Given this list of marker genes ABCA3, CHAT, SLC9A6, TYMP, CTCF (CCCTC-binding factor), TSEN2, GABRA2, ORC1, CACNA1A, PSPH, CACNA1I, CENPT, GEMIN4, CHD7, ATP11A, CORO1A, DNAAF4, TGIF1, COL5A1, SNAP25, GABRD, CCDC22, FOXG1, ABCD4, WWOX, DYRK1A, ATP7A, DDOST, PLCH1, NRXN1 (NCBI Gene Id 9378), GP1BB, MMP1, TRMT10C, TWNK, PRUNE1, AMER1, TSPYL1, ARSL, TRAPPC12, CDK19, MAP3K7, ARVCF, NTRK2, GBA1, PHOX2B, EDEM3, PIK3CD, SFTPC, ITPR1, SLC6A5, PHGDH, EBF3, ATN1, SLC6A3, NONO, HNRNPH1, CAMTA1, SPTSSA, POGZ (NCBI Gene Id 23126), UFD1, LONP1, VPS35L, VPS37D, ERMARD, FZD2, ZNF699, ZBTB18, TRPV6, COX11, SEC63, FBN1, PGM3 (phosphoglucomutase 3), RREB1, ALG9, NUP62, RPL10, GABRG2 (NCBI Gene Id 2566), DHX9, IL7R, MGAT2, IQSEC2, CLIP2, DPYSL5, FOXP2, CDKN1A, PI4KA, SEC23A, NDUFA13, TRIP4, NALCN, MAPK1, KCNC2, SOX5, KNSTRN, JMJD1C, ALG2, DSP, ARF1, CEACAM6, CDKN2B, TMEM270, RARS2, FGF12, RRM2B, PRMT7, KCNQ3, KMT2A, ELP1, FBXO11, SLC35A2, BAZ1B, CACNA1C, PDPN, CTHRC1, NSUN2, ACTL6B, GTF2I, GABBR2, LETM1, TFAP2A, FZR1, LUZP1, MSL3, SRCAP, SLC38A3, GLYCTK, PARS2, PRKCSH, GLRB, FARSB, POLR2A, ATL1, GABRA5, GRIN1, IFT56, LMNA, DALRD3, PSAP, CRIPTO, IRF5, GRIN2D, ZIC2, KIF1A, CACNA2D1, DPH5, DHDDS, MMP23B (matrix metallopeptidase 23B), SUCLA2, DDB1, PIGT, COL1A1, NSD1, ATP9A, TSEN15, CNTNAP1, GTF2IRD1, TCF4 (transcription factor 4), ZBTB7A, RAI1, SLC25A24, GMNN, ATP6V0A1, HSPG2, ORC4, TCEAL1, FMR1 (fragile X messenger ribonucleoprotein 1), KAT6B, SIX3, METTL27, STIL, SYT1, SEPSECS (NCBI Gene Id 51091), COL7A1 (NCBI Gene Id 1294), TMEM94, HECTD4, APC2, CACNA1B, STAC3, H3-3B (H3.3 histone B), RNU4ATAC, KMT2B, UBA5, FLNA, GRIA1, EXT2, CSPP1, SMC5, SYT2, SCN3A, ADAMTSL2 (NCBI Gene Id 9719), CTBP1, NRCAM, CAV1, BLM, CAMK2B, KDM6A, SMG9, SNRPB, PIEZO2, ERCC8, LYRM4, PTCH1, WNK1, NSD2, ERF, FLCN, ATL3, UFC1, GTF2IRD2, RET, DHCR7, FAM13A, STAG2, ADAT3, SSR4, SFTPA2, CHRNA3, KCNAB2, MRPS34, FOXH1, CCN2, KIAA0586, CHMP1A, HCN1, POR, ADNP, SLC1A2, RNF125, TYMS, MSR1, TRAK1, MUC5B, GNAS, CELF2, DNM1, KCNA2, ASCL1, NPHS1, CLTC, RHBDF2, MYT1L, LRPPRC, WAC, FKBP6, POLG (DNA polymerase gamma, catalytic subunit), SI, KMT2C, GON7, CNKSR2, COL4A6 (collagen type IV alpha 6 chain), MED12, SALL1, PRDM13, SPEN, NUP214, CCDC47, ERCC6, TBC1D24, CPLX1, NODAL, SH2B1, AFF4, SLC26A9, HIRA, CPSF3, SON, AASS, ASCC1, ARCN1, USP7, H3-3A (NCBI Gene Id 3020, H3.3 histone A), KMT2D, TAF1, PACS1, KCNB1, MIF, ATRX, ELN, VAMP1, SRPX2, HDAC8, MAB21L1, NCF1, BRD4, SFTPA1, SLC9A3, COG7 (NCBI Gene Id 91949), SMC3, ASPA, AGRN, ADGRG1, SLC19A2, GNB5, HNRNPH2, PORCN, PHIP, ASXL1 (ASXL transcriptional regulator 1), MED25, PAK1, CFTR, DMPK, PACS2, TOP3A, AARS1, AFF3, TERC, MYH11, SLC18A3, AP3B2, ALDH18A1, WDR26, NUS1, PIEZO1, MAPK8IP3, SMC1A, STAT6, SLC1A4, NUP54, PUF60, PPM1D, EHMT1, SEC24C, KCNH1, ARID2, SLC13A5, CCR6, NECAP1, DCTN4, AGO1, CDON, SYNGAP1, PRDM16 (NCBI Gene Id 647868), ASNS, CDC6, NEPRO, KCNN4, HRAS, SEMA3E, PPP3CA, HLA-DRB1, COL4A5, NOS1, GABRB2, SLC6A14, SPTBN4, TMTC3, LRP5, DISP1, KCNQ2, ADAMTS2, YWHAG, SHH, EP300, DLL1, GRB10, CDK13, SLC25A1, HLA-DQA1, ITCH, MLXIPL, LAMA2, CYFIP2, UBE4B, MAGEL2, TBL2, LTBP4, MBD5, SLC37A4, COMT, SCN9A, ZSWIM6, CDKL5, MID1, EEF1A2, MCEE, SCN8A, TGFB1, RTEL1, ACADVL, SPTAN1, SATB2, TAF6, PCGF2, MECP2, CDKN1B, CLCA4, SKI, CEACAM3, COL5A2, FGFR3, TBX1, STX1A, PRKCZ, LBR, MPV17, ATP1A2, PYCR1, CREBBP, FCSK, GLI2 (GLI family zinc finger 2), GSTM3, USP9X, ADAR, SIAH1, ATP1A3, DST, H4C5, MAP1B, HNRNPK, SLC25A4, CLCN4, SPOP, MEN1, SMARCA2, FGF8, EDNRA, HLA-DQB1, GPHN, COL13A1, ATP6V1B2, DPP9, NACC1, PDHA1, IPO8, GALC, SLC11A1, ATP6V1A, OCRL, NIPBL, AFG2A (NCBI Gene Id 170576), KAT6A, TSEN54, ZMYM3, AGO2, ARV1, DDC, RETREG1, TWIST1, CHAMP1, BRAF, DEAF1, MYO1H, FGFRL1, PARN, FBXW7, COL2A1, BUD23 (BUD23 rRNA methyltransferase and ribosome maturation factor), TSEN34, CDKN2C, MEIS2, RNU4-2, BICRA, TERT, STAT3, LIMK1, DNAJC30, ALG12, SEC31A, SUCLG1, HIVEP2, GAS1, NEXMIF, FGFR1, MEGF10, SLC2A10, ORC6, SUPT16H, STN1, MYMK, SZT2, LIG3, SATB1, FBXO28, SLC46A1, POLG2, PIGN, RERE, MED12L, TBX4, SERPINA1, CASZ1, SAMD9, ASXL3, GCLC (glutamate-cysteine ligase catalytic subunit), SHANK3, SLC5A7, KIAA0319L, NFIX, SLC12A2, MT-ATP6, GLRA1, ARFGEF2, SCN1A, EIF4H, TECPR2 (tectonin beta-propeller repeat containing 2), ATAD1, BMP4, CLP1, LIG4, FLII, SYNJ1, TIMM22 (NCBI Gene Id 95988), RAD21, CRLF1, SV2A, ALMS1, RFC2, FBXL4 (NCBI Gene Id 26235), AGR2, EIF5A, HMOX1, SPTLC1, ARNT2, NEDD4L, MYO9A, HFE, SPTLC2, SIN3A, WASHC5, AP3B1, STAG1, here is a description of the gene set: Human Gene Set: HP_GASTROESOPHAGEAL_REFLUX Gastroesophageal reflux species: Homo sapiens A condition in which the stomach contents leak backwards from the stomach into the esophagus through the lower esophageal sphincter.